Given this list of marker genes SLC37A2, CEBPB, SLC17A7, SFRP4, XPR1, FGFR1, CLDN3, SLC34A3, SLC17A4, SLC34A2, VDR, SLC20A1, FGF23, ATF4, SLC34A1, SLC17A8, SLC20A2, SLC37A3, SLC17A1, ANKH, SLC25A3, CRY2, SLC37A1, SLC37A4, SLC25A10, SLC17A3, SLC17A6 (NCBI Gene Id 57084), here is a description of the gene set: Human Gene Set: GOBP_PHOSPHATE_ION_TRANSPORT species: Homo sapiens The directed movement of phosphate ions into, out of or within a cell, or between cells, by means of some agent such as a transporter or pore.